The following is a description of a gene set: The Smad2 and Smad3 (Smad2/3) proteins are principally involved in the transmission of transforming growth factor beta (TGF-beta) signaling from the plasma membrane to the nucleus. Many transcription factors have been shown to cooperate with the Smad2/3 proteins in regulating the transcription of target genes, enabling appropriate gene expression by cells. Here we identified 1,787 Smad2/3 binding sites in the promoter regions of over genes by chromatin immunoprecipitation on microarray in HaCaT keratinocytes. Binding elements for the v-ets erythroblastosis virus E26 oncogene homolog (ETS) and transcription factor AP-2 (TFAP2) were significantly enriched in Smad2/3 binding sites, and knockdown of either ETS1 or TFAP2A resulted in overall alteration of TGF-beta-induced transcription, suggesting general roles for ETS1 and TFAP2A in the transcription induced by TGF-beta-Smad pathways. We identified novel Smad binding sites in the CDKN1A gene where Smad2/3 binding was regulated by ETS1 and TFAP2A. Moreover, we showed that small interfering RNAs for ETS1 and TFAP2A affected TGF-beta-induced cytostasis. We also analyzed Smad2- or Smad3-specific target genes regulated by TGF-beta and found that their specificity did not appear to be solely determined by the amounts of the Smad2/3 proteins bound to the promoters. These findings reveal novel regulatory mechanisms of Smad2/3-induced transcription and provide an essential resource for understanding their roles. from publication Koinuma D, Tsutsumi S, Kamimura N, Taniguchi H, Miyazawa K, Sunamura M, Imamura T, Miyazono K, Aburatani H (PMID 18955504) studied in species Homo sapiens Genes with promoters occupied by SMAD2 or SMAD3 in HaCaT cells (keratinocyte) according to a ChIP-chip analysis. Human Gene Set: KOINUMA_TARGETS_OF_SMAD2_OR_SMAD3, and this is the list of marker genes: LNX2, LYPD1, PLEKHA1, KRT4 (keratin 4), PLD1, CEMIP2, BCAR3, PIM1, IER3, FCHO2, GPNMB, FKBP1A, TAGLN2, BAZ1B, EPHA2, PERP, LPAR1, MAST4, SH3PXD2A, NEDD4, DKK3, MAL2, TUBB6, GPR87, NFIL3, PRSS23, EXT2, SIN3A, TM4SF1 (NCBI Gene Id 9004), HBEGF, SULT1A3, GPRC5A, RIN3, KDM3A, RABL2B (NCBI Gene Id 11158), CLIP2, NET1, ARL14, SPATS2L, PLEK2, ST7, TXNRD1, CALM2, SIGIRR, EMP1, SLC7A8, NPC1, CIPC, DENND2C, TUBB, RTTN, F3, ITGAV, CREB3, SMPD4, HOXA3, TJP2, ABCA5, CDK5, SIAH2, EIF4E, TCF4, MAPRE2, H2AC18, MYO10, SNRPE, CHD3, MGST3, MMP9, HOXC6, CD44, ABCF2, BCAT1, PHLDB1, ARL4A, PPP1R13L, GALNT11, DEPDC7, TRAF7, CYP27C1, CDC6, RAPGEF1, ACTR3B, ITGBL1, CDKN1A, GRHL3, SLC7A5, RUNX1, PHF19, GNG5, TUFT1, MTMR11, TSKU (tsukushi, small leucine rich proteoglycan), BAIAP2L1, LSM10, CLTC, TRAM1, PTHLH, ANKS6, PLEKHG3, WASF2, WDFY3, TNPO1, THBS1, SMIM3, KRT7-AS, GLS, FANK1, TUT4, SFN, ZNF592, UPP1, MIOS, RCC1L, KMT2C, EDN1, FGD3, SNX5, NFE2L1, IL1RL1, AKAP13, PARP4, BRIX1, CCN2, SERPINB2 (serpin family B member 2), HOXA10, MMP10, SERPINE1, BLCAP, RAD9A, SERINC2, MPZL1, CKMT1B, DAPP1, TNFRSF1A, DSC2, MEAK7, RAD1, EPN2, PC, POLG, TLE1, SARAF, EIF4H, MBD4, CLDN4, PTPN21, BABAM2, SLC37A2, CAMKK1, DAB2IP, HSPE1, PAK6, PPA1, KRT17, WWTR1, SMAD3, SLX1B (NCBI Gene Id 79578), PIK3C2B, C8orf58, TTL, ZNG1A, ENO1, IFNGR1, INO80C, PIP5K1A, RASA2, KPNA1 (karyopherin subunit alpha 1), RBKS, LAMB3, ARHGDIB, NXT1, TUBB2A, EIF2S1, ACAD9, GATA3, MYO5B, FOXO3, TRAPPC3, ABR, KLC4, RIOK3, AKIRIN2, YWHAZ, PRRG4, GADD45A, RAB38, UBQLN1, DSG2, RBPJ, TINAGL1, ABHD2, SPECC1, BUD23, SH3RF1, RNH1, FHL2, EEF2KMT, PHF13, VPS13C, AGAP3, APOBEC3B, PPIP5K1, MXRA7, CNTNAP3, DENND2B, PLXNA2, PEX13 (peroxisomal biogenesis factor 13), NUP42, VCL, NHS, ETS1, CCL2, KRT19, ANKRD10-IT1, LIMK2, ARID3B, S100A10, TBX3, NME1, PAWR, YAP1, IRX4, FEM1B, ZSCAN25, PLAU, SERPINB7, MDFI, SPAG9, PPT2, TCEA1, MISP, STK10, KCNK1, ANXA2 (NCBI Gene Id 792), COPS8, RHEBP1, ATP6V1E1, ITGB1, TBL2, CAPNS1 (NCBI Gene Id 826), WWC1, COL12A1, HSDL2, RAP2A, GLUD1, PTPRK, PPP3CA, SLC7A6, TMEM170A, MAP3K14, DSTN, CLSTN1, DNAJC2, SCNN1A, SUN1, NCEH1, LAD1, C15orf39, WDR81, STK17A, ZMYND8, SULF2, ARHGEF37, RIPK4, NEDD4L, DCLRE1B, MKKS, AGGF1, PTBP3, FAT2, KIFC3, IRF2BP2 (interferon regulatory factor 2 binding protein 2), CLU, OSBPL7, C1orf116, SAMD9, JUP, ARHGAP32, MBTD1, DRAP1, MAFK, IKBKG, UBC, KRT5, DUSP10, RMI1, YME1L1, ELL2, CTBS, ADGRF1, NSUN5, TMOD3, SNAP23, OLR1, BACH1, H2AZ2, ACOT2 (acyl-CoA thioesterase 2), CD55, TMEM87B, OSBPL3 (oxysterol binding protein like 3), RBM25, SLC39A13, SETBP1, KRT7, CEP57, KLF10 (KLF transcription factor 10), SLC25A24 (solute carrier family 25 member 24), USPL1, TNFRSF12A, DENR, MZT2B, CAV1, TRIM56, TMEM87A, METTL17 (methyltransferase like 17), PHLDB2, PPP2R2D, C9orf78, ECH1, BCR, LINC01089 (long intergenic non-protein coding RNA 1089, NCBI Gene Id 338799), RASSF5, TFAP2C, ABL1, HNRNPH3, GSPT1, IRF2BPL, GANC, CORO1C, ANXA8, RFC2, ST6GALNAC4, NDRG1, HERPUD2, ANLN, RDH11, MSANTD3, TRUB2, TRIM32, DHX32, AIFM1, CMIP, LGALS8, TPD52, NOTCH2, MDC1, BLZF1, MOB4, FKBP2, FOSL1, MBOAT2, TNC, MICALL1, WNT9A, ENC1, IST1, VPS35, BCL9L, TXN, TGM2, ABLIM1, CBX3, SNAI2, HSPA5, STAM2, SLC7A1, LIMA1, IRF6, OCLN, MALT1, NME2, CGN, RAP2B, PSMC2, CBL, KLF7, COBLL1, TRIM25, UBE2R2, MFN2, NUDT18, MELTF, DST, SYNE2, HCAR3, NFKB1 (nuclear factor kappa B subunit 1), LNPEP, CNIH1, ZNF462, CASP1, ATF3, SMURF1, ACYP1, KRT13, SMURF2, OVOL1, KRT15, VIM, HOXA7, NDE1, DMTF1, MET (MET proto-oncogene, receptor tyrosine kinase), KANK1, TGFBI, LINC01503, FADS1, SMG1, MNT, PRR15, SESTD1, GUSBP14, KNOP1, PICALM, NUDCD3, PRNP, PKM, SAV1, CLDN7, EHF, CDV3, CHMP4B, SYK, DHRS3, AP1S2, CCP110 (NCBI Gene Id 9738), CD109, PTP4A1, FASTK, CTNNAL1, KLF3 (NCBI Gene Id 51274), YOD1, SUSD6, POLR1D, RSPRY1, TJP1, IVL, CHD9, KCTD1, GOLM2 (NCBI Gene Id 113201), TMEM80, PML, RGS12, HELZ, HNRNPA2B1, NPTN, PTPRB, PNMA1, PURB, DSG3, NME7 (NME/NM23 family member 7), GNB5, SMG7, EDIL3, RPL24, GSE1, UFD1, ADK, MTFP1, H2BC21, IVNS1ABP, ADAM19, ZFP36L1, BCL7B, ACTN1, NPTN-IT1, DOCK5, S100A2, PNP, PRKAG2, PLOD2, LAMC1, SNX7, ADM, RIN1 (Ras and Rab interactor 1), DEDD, SERTAD2, ANXA3, SLC49A4, PRSS22, SDR16C5, ATP1B3, YARS1, KPNA4, PRDX1, AMOTL1, SMOX, ARRDC1, SGPL1, PFN1, MPZL2, BTG2, EXTL2, PCDH1, GTF2IRD1, TSPAN15, PSMD14, SULT1A1, SEC14L2, RAB4A, ANKRD10, TAX1BP1, UBE2D1, THOC6, PTGFRN, MFSD12, PTK2, EDAR, KIAA0753, GSS (NCBI Gene Id 2937), NDST1, VDAC2, DTL, HNRNPUL1, PRKCH, DNAJC25, CALD1, S100PBP, COL7A1, SPRED1, JMJD1C, ZW10, RHOD, SFR1, ELK3, STARD4, QKI, MICALL2, SLC4A2, HNRNPH1, SLC20A1 (solute carrier family 20 member 1), RCBTB1, MIRLET7BHG (NCBI Gene Id 400931), STON2 (stonin 2), PFKFB2, F11R, SLC35F2, TFPI2, SLC48A1, ZNF335, MCL1, INSIG2, AFDN, SGMS1, COQ4, B3GNT5, PKP2 (NCBI Gene Id 93271), SERPINB8, POLR1G, ORC6, MBOAT1, PRXL2A, ARHGAP21, TSC22D2, SERF1A, AKIP1, FST, BTBD7, SMAD7, TIPARP, CASZ1, GBA1, GABARAPL1, DENND1B, DSE, MAP2K3, SSBP3, AMOTL2, TBC1D2, MASTL, CTPS1, LTBP3, CXXC5, ATXN1, RHOC, SPIN1, COQ2, BLOC1S2, ENAH (ENAH actin regulator), SMC2, TLCD3A, SLC9A1, GPC1, THBD, AEN, MTHFR, SH2D4A, GPR39, SERPINB5, POLD4, DYNLT2B, FUBP1, NSFL1C, WEE1, ORMDL3, PDLIM1, CPSF6, MARK3, SLC25A28, THADA, KRT8, MT2A, F2RL1, MORF4L1, SMAD6, REPIN1, ZC3H12A, NOTCH2NLA, GAD1 (glutamate decarboxylase 1), TEDC1, IFRD1, NPIPA1, TSC22D1, RXRB, DSG4, LRRC37B, OLFML2A, CCN1, ZNF143, SCRN1, GTF2IRD2, NUCKS1, ETS2, DACT1, PRDM10, IL4R, MEF2A, BRD2, AHR, SREBF1, RIN2, TFAP2A, POGZ, EFNA1, PTGES, GTF2H2, CLCF1, NFX1, DSP, POLR2J, BTBD10, STX6, B3GALNT2, PMEPA1 (prostate transmembrane protein, androgen induced 1), DNAJB2, SHLD2 (NCBI Gene Id 54537), HCFC1R1, HNRNPK, SPRED2, TBC1D15, TMEM259, SLC35D1, TMBIM1, AP3S1, ID1, MGME1, NIBAN2, HOXA5, TLN1, PLS3, AHNAK, ZDHHC3, CPNE2 (copine 2), FAM86C1P, CSRNP1, FAM76B, CDC45, DUSP14, VTI1B, RNF168, SLX4IP, ATAD2, FGD2, AFAP1L2, MAN1B1, HOXD11, IGFBP3, LGALS3, FLOT1, ATG12, ANO1, RDH13, OSBPL1A, ARFGAP3, SMAD1, MYOF, VPS35L (VPS35 endosomal protein sorting factor like), MARVELD1, FURIN, BNC1, TGIF1, ANXA4, JUNB, ALCAM, RABGAP1, TGFA, ARID2, MAPK6 (mitogen-activated protein kinase 6), HES1, ACADVL, PISD, SKIL, DENND4A, COTL1, CDC42EP3, CAST, DUSP6, ARID1A, MOB3B (MOB kinase activator 3B), FERMT1, UHRF1, ARHGEF3, MAPK8, TRIM8, FOSL2, NQO2, KRT6A, NANP, FAM217B, ANTXR2, PCBP1, ARHGEF5, PLP2, FAM107B, ABCB6, CXCL6, KBTBD2, MBNL1, PRKAB2, IL18, SBDS, GTF3C5, MALAT1, CYP26B1, TRA2B, LEO1, CERK, PLEC, ZBED2, SUSD1, FAM83A, TMCO3, MYH9, H2BC7, NBPF14, KRT80, ZNF148, RASAL2, CD59, SLC38A2, MCFD2, UGT1A10, GPN1, RANGAP1, INTS7, HS3ST2, SVIL, PHLDA2, KLF6, ZFP91, AGPS, ZNF703, CLIP1, ACOX1, MAML2, PALM2AKAP2, ZNF362, EGFR, MITF, PARP8, EXT1, UTP25, SEPTIN9, CRABP2, TBK1, MRPL2, RTN4, LAMC2, ATP6V1D, CDCA4, FRMD6, GTF2I, SLC1A3, DEAF1, RPL3, PTPRF, NUB1, GDE1, SLC30A7, WDR89, SAT1, TES, H2AC11, RGPD5, LRRC61, COL17A1, MBNL2, BCL2L11, GNG12, POLR2J4, SPTBN1, CARNMT1, CIRBP, WBP4, CHPF2, SRI, HIC2, ITGA2, KCNJ15, HIP1R, APOO, DNAJC30, PTPRU, SRSF3, TBL1XR1, ADGRG1, SLC4A11, FAR1, ADAMTS6, BMPR2, AP4B1, C3orf52, ITPRIP, MYC, KRT14 (NCBI Gene Id 387571), TYW1, PLCXD2, AKR1C1, TSTD1, WASH9P, NT5E, RING1, GNG10, CEP350, CFAP68, SERTAD4, BTG1, INPP5A, DCAF11, LTBP2, FAT1 (FAT atypical cadherin 1), EIF4A2